Given this list of marker genes Myh10, Fgf2, Fos, Mapk1, Yap1, Nrg1, Gja1, Paxbp1, Tbx1, Myog, 2810429I04Rik, Tenm4, Smad1, Dyrk1a, Abl1 (NCBI Gene Id 98922), Ccnd2, Nkx2-5, Mir133a-1, Gata6, Rxrb, Mir1a-2, Hgf, Pten, Cflar (CASP8 and FADD-like apoptosis regulator), Ctnnb1, Angpt1, Cited2, Mstn, Sugt1, Zfpm2, Kcnk2, Mef2c, Arid2, Cav2, Ppard, Trp73, Notch1, Ephb1 (NCBI Gene Id 270190), Rxra, Mir133a-2, Ndc80, Hey2, Tgfbr3, Six1 (NCBI Gene Id 20471), Mapk11, Dipk2a, Gli1, Pim1, Ski, Selenon, Tgfb2, Stat3, Ncam1, Foxc1, Foxc2, Shh, Hdac2, Tgfbr1, Apc, Rtl1, Erbb4, Akirin1, Foxp1, Fgf20, Megf10, Gata4, Sirt1, Fes, Tbx2, Dsn1, Cdk1, Mapk14 (mitogen-activated protein kinase 14), Rbpj, Kpna1, Jarid2, Cxadr, Nog, Snhg15, Prkar1a, Sav1, Bmpr1a, Wnt2, Jak2, Six5, Tgfbr2, Fgfr1, Rbp4, Fgf1, Tbx5, Fgfr2, Tbx20, Vgll4, Bmp10, Ccnb1, Fgf9 (fibroblast growth factor 9), Src, here is a description of the gene set: Mouse Gene Set: GOBP_STRIATED_MUSCLE_CELL_PROLIFERATION species: Mus musculus The multiplication or reproduction of striated muscle cells, resulting in the expansion of a cell population. Striated muscles contain fibers that are divided by transverse bands into striations, and cardiac and skeletal muscle are types of striated muscle.